Given this list of marker genes Tesc, Chi3l1, Il34, Xbp1, Gsdmd, Cdk4, Lrp1, Wnt11, Rbm22, Larp1, Card11, Mapk14, Ahi1, Cd86, Ly96, L3mbtl3, Mapk13, Mettl8 (NCBI Gene Id 228019), Ago3, Anxa1, Edar, Slc11a1, Mir23a, Grhl3, Kmt2a, Il17d (NCBI Gene Id 239114), Fcgr1, Rftn1, Kdm2a, Mir301, Slc26a9, Mef2c, Ogg1, Polr2a, Lcor, Sulf2, Mycn, Ptpn22, Ago2, Gdnf, Hif1a, Xcl1, Riok3 (RIO kinase 3), Camp, Cd40, Dnd1 (NCBI Gene Id 21746), Prr16, Iqgap3, Dkk1, Cd200 (CD200 molecule), Itga2, Plxnb2, Garin5a, Ythdf3, Slamf1, Oas1d, Cpeb3, Brca1, Rbm14, Nmbr, Nkx2-5, Mir505, Trappc2, Ngrn, Akap6, Il17rc, Dnaja4, Cd209d, Zc3h14, Hgf, Ago1, Stoml2, Foxp3, Whrn, Nup98, 4930480E11Rik, Cd40lg, Samd4, Tnp1, Icosl, Gsk3a, Mbl2, Ccl19, Sh3pxd2b, Il27ra, Il15, Smyd5, Boll, Hnf1a, Alkbh1, Cadm1, Gm7324, Apobec1, Il13, Unc93b1, Wnt7b, Csf2, Tlr7, Clec12a, Fcgr3, Adam3, Csf1, Cnbp, Slc38a2, Nlrp1b, Eif3d, Ntrk3, Tmed2, Rhbdd1, 4931414P19Rik, Vegfd, Hnrnpc, Erbb2, Samd1, Il20rb, Il12rb1, Sgms1os1, Cd209b, Sh3bgrl, 6030468B19Rik, Alox8, Nsun5, Erbb3 (erb-b2 receptor tyrosine kinase 3), Prkca, Flt3, Kpna6, Cnn2, Nkx2-1, Hmgb1, Runx2, Wdr77, Nr5a2, Cxcl17, Klk5, Cd55b, Pkd2, Rbm4b (NCBI Gene Id 66704), Kdm1a, Ptk2b, Reg1, Il6, Eif4g2, Igf2bp3, Cd36, Ceacam20, Psg18, Ifi203-ps, Id4, Frmd8, Robo1, Pms2, Smarcd1, Ptafr (platelet-activating factor receptor), Pcif1, Aldh1a2, Cd44, Sting1, Eif4g1, Prg3, Sphk2, F2rl1, Hspb1, Ptgfr, Crhr2, Alkbh4, Adam8, Mzb1, Myocd, Adtrp, Mapk3 (NCBI Gene Id 26417), Fgfr4, Mmp8, Abcc8, Irak3, Rpl23, Nat10, Rpl5, Prkdc, Tlr3, Ash2l, Slc35a4, Adam17, Ifi213, Cebpb, Lin28a, Gsk3b, Epx, Prkch, Tgfbr3, Nodal, Pqbp1, Etv2, Gria1, Zc3h12a (zinc finger CCCH type containing 12A), Mapk1, Ppard, Ccl1, H2-Q7, Lrrk2, Timm23, Mapk8, Nos2, Hoxa5, Rbm10, Anxa2, Ccn1, Adra2a, Fam98a, Nod1, Adam19, Hnrnpa0, Pde2a, Panx3, Bsg, Dhx33, Tmem119, Trp53, Smad4, Rasgrp1, Apob, Stox1, Mcoln2, Pla2g3, Zfpm1, Rpusd3, Chuk, Pdcd5, Hnf4aos, Pibf1, Stat5a, Ifngr1, Klrk1, Serpinb7, Rps7, Dnmt3b, Tnfrsf14 (NCBI Gene Id 230979), Pip, Nr1i2, Cyrib, Cd6, Gjc2, Bmp6, Mir184, Phb1, Ephb2, Sirt7, Elane, Exosc6, Barhl2, Mkx, Lck, Dhx34, Casp8, Tnfrsf1a, Cyp2j6, Setx, Tnfsf9, Npm1, Fam47c, Mir361, Cd160, Hes1, Prpf19, Lrrfip2, Fus, Tarm1, Ripk1, Hyal2 (hyaluronoglucosaminidase 2), Hnrnpab (heterogeneous nuclear ribonucleoprotein A/B), Rbp4, Il4ra, Trem2, Oas3, Wnt7a, Men1, Prkn, Tada3, Cd2, Mtor, Rab3gap1, Smad2, Ngf, Nck2, Arfgef2, Cd28, Chia1, Tob1, Cdh3, F2r, Smo, Sash3, Ccl4, Trmt112, Lef1, Il17a, Otud6b, Mup5, Cyp3a13, Isl1 (ISL1 transcription factor, LIM/homeodomain), Hnrnpa1, Myh9 (myosin, heavy polypeptide 9, non-muscle), Dgkq, Fn1, Uqcc2, Serp1, Eif5a2, Il2rg, Slc6a4, Ctcf (CCCTC-binding factor), Card9, Dicer1, Pdgfb, Tet1, Dlk1, Hk1, Flot1, Creb3l2, Raet1d, Agtr1a, Plgrkt, Hinfp, Eloc, Tlr4, Pycard, Zbtb20, Hpn (hepsin), Tlr5, Rarg, Plscr1, Nkx2-2os, Klk7, Ppp3ca, Itgb3 (integrin beta 3), Rif1, Pkp3 (NCBI Gene Id 70182), Mpl, C5ar1 (complement component 5a receptor 1), Trim56, Nfe2l2, Il2, Hand2, Il23a, Trub1, Eif4a3l2, Pid1, Slamf6, Nwd1, Cd84, Slc39a5, Trim6, Crh, Nox1, Il4, Eif4enif1, Wnt16, Pnp, H2-M3, Mir18, Ifnb1, Ifih1, Atmin, Rbpj, Gimap5, Cebpg, Arnt, Pink1, Il9, Nsun4, Spn, Kpna2rt, Fgf2, Gper1, Dhx29, Akt1, Hnrnpd, Rbmyf6, Malt1, Tigit, Rbm46, Dgcr8, Tnfsf11, Nras, Atf2, Drosha (NCBI Gene Id 68645), Usp16, Ltb, Hilpda, Phb2, Elavl1 (NCBI Gene Id 97501), C1qtnf4, Tcf3, Prdx6b, Batf, D1Pas1, Mmp14 (NCBI Gene Id 17387), Hnf4a, Adam2, Sirt1, Pla2r1, Hspa8, Agpat1, Pabpc1, Gdf2 (NCBI Gene Id 12165), Rdx, Rbmxl1, Fgfr2, Il12rb2, Actg2, Panx1, Htr2b, Sphk1, Mndal (myeloid nuclear differentiation antigen like), Scrib, Pik3r1, Lin28b, Eda, Lrrc32 (leucine rich repeat containing 32), Ldlr, Ikzf1, Vdr, Cd244a, Nlrp9b, Wnt5a, Dnmt1, Pagr1a, Cd3e, Sptbn1, Eif2ak4, Tank, Rlf, Adar, Ifnar1, Pou3f3, Map2k2, Vps72, Arrb2, Tmem135, Musk, Nfkb1, Gas6, Trub2, Pomc, Tgfb1, Cldn5 (NCBI Gene Id 21920), Foxp1, Mylk2, Ccr7, Gata5, Pnp2, Pik3cd, Pth, Map3k7, Rnf207, Krt17, Jag1, Traf3ip2, A1cf, Ccbe1, Osr2, Pou2f2, Mettl5, Prmt1, Ptprj, Pou2af1, Prg2, Myd88, Srpk2, Il12a, Kat2a, Cdh5, Lamp3, Rps6ka2, Kdm3a, Rpl11, Rab7b, Bmyc, Mapkapk2, Hnrnpll, Rbm3 (RNA binding motif (RNP1, RRM) protein 3), Sulf1, Msh2, Hspd1, Mup11, Amh (NCBI Gene Id 11705), Serpine1, Ins2, Tbx21, Med1, Fam47e, Aicda, Fshb, App, Ythdf2, Ccdc88b, Cebpe, Nlrp1a, Slc24a4, Ptger4, Irf8, Casp1, Smad1, Rhox13, Ncoa3, Wnt6, Tfrc, Rps3 (ribosomal protein S3), Larp4, Habp4, Stx4a, Eif2ak3, C3ar1, Aire, Eif6, Hpx, Slc24a3, Brd7, Sox10, Cdkn2a, Adm2, Piwil2, Lacc1, Lrp3 (NCBI Gene Id 435965), Qki, Pabpc1l, Zar1, Trim65, Pparg (peroxisome proliferator activated receptor gamma, NCBI Gene Id 19016), Rps6kb2, Atad5, Bmp4, Emilin1, Crp, Exosc10, Rbfox2, Foxc1, Inhba, Hsf1, Mdk, Hc (hemolytic complement), Zmpste24, Mad2l2, Hfe, Stmp1, Prkd2, Mbp, Mapk9, Ddit3, Rara, Il1rl1, Brdt, Tomm70a, Zswim8, Tusc2, Clec9a, Eno1, Uap1, Tent5b (terminal nucleotidyltransferase 5B), Ctnnb1, Mirlet7a-1, Chrna7, Thrap3, Il5, Prdx6, Dnajc3, Trp53inp1, Rbmyf3, Tlr1, U2af2, Vsir, Spi1, Wnt3a, Mef2a, Ddx1, Polr3c, Nrl, Nr1h4, Mir452, Ffar2, Peli1, Tnc, Il18r1, Sgf29, Rbbp5, Park7, Agr2, Cldn3, Bcl10 (B cell leukemia/lymphoma 10), Rbmyf9, Avpr2, Ddx39b, Igf2bp2, Tlr8, Mecp2, Sry, Crtam, Csf1r, Afap1l2, Mir125b-2, Sod1, Pld1, Oas1c, Eif5a, Cd300c2, Nfatc1, Osm, Ankrd42, Hoxd3, Lilra5, Trpv4, Rela, Gapdh, Nlrp3, Nr0b2, Il17f (NCBI Gene Id 96930), Tet2, C1qtnf3, Iapp, Met, Il16, Bmp7, Sox17, Pik3cb, Phactr1, Lum, Pym1, Polr3f (polymerase (RNA) III (DNA directed) polypeptide F), Syncrip, Rps4x, Fam76b, Rsad2, Tirap, Hnrnpk, Egf, Epb41l4b, Cyba, Hdac2, Mup3, Oas1h, Dhx36, Mir466l, Usp50, Ar, Ptgis, Cntn1, Ncl, Ppp1r15a, Txk, Ets1, Id1, Eif4a3, Shh, Oas1g, Dll4, Rbm24, Clns1a, Fxr2, Dyrk1a, Atp13a2 (ATPase type 13A2), Cux2, Adcyap1, Prkcz, Atf3, Fcer1g, Igf2bp1, Dennd1b, Paip1 (NCBI Gene Id 218693), Cd83, Crebbp, Sox4, Kdm6a, Lpl, Ddx3x (NCBI Gene Id 236681), Plcg2, Itgb8, Arx, Bcl11a, Itga3, Fzd5, Spon1, Upf3a, Fastkd3, Eif4g3 (eukaryotic translation initiation factor 4 gamma, 3), Smarca4, Mark1, Wnt8b, Rora, Usp22, Tradd (NCBI Gene Id 71609), Setd1a, Klf4, Csde1, Pkp1, Jmjd4, Lurap1, Tek, Chil5, Itgax, Rad21, Stat1, Bmpr1a, Pdcl3 (NCBI Gene Id 96896), Eif2ak2, Fev, Tnfrsf4, Adipoq, Myt1, Eno1b, Ccl3, Bcl3, Il1rl2, Fadd, Cd27, Tnfsf18, Tmem106a, Trp53bp1, Il1a, Vip, Cdk6, Nog, Twist1, Il27, Traf3, Runx1, Fcer2a, F3, Agpat2, Rps27l, Ep300, Mmp12, Ctnnd1, Nos3, Mavs, Ctsh, Sox9, Abl2, Defb25, Rnf135, Sox8, Cd226, Smarcb1, Tent5c, Mettl14, Usp21, Hand2os1, Tgfb2, Ogt (O-linked N-acetylglucosamine (GlcNAc) transferase (UDP-N-acetylglucosamine:polypeptide-N-acetylglucosaminyl transferase)), Trim15, Tent2, Cirbp, Ephx2, Ifi209, Il18 (NCBI Gene Id 16173), Glyr1, Dazap1, Mir324, Snrnp70, Nr3c1, Actc1, Cd1d1, Bcdin3d, Il17rb, Terf2, Snw1, Wnt10a, Prkag1, Guf1, Tgfb3, Il17c, Kpna7, Elavl4, Sgms1, Hmgn5, Oas1e, Poldip3, Carmil2, Fubp3, Rpusd4, Spry2, Tgfbr1, E2f1, Slirp, Panx2, Mafg, Btk, Notch1, Calcr, Mst1, Rab2b, Exosc3, Rps6kb1 (NCBI Gene Id 72508), Fgf9, Ulbp1, Nrde2, Tmed10, Pax6, Alox12b, Nat8b-ps, Astl, Itk, Mefv, Gapdh-ps15, Prdm1, Gata3, Casr, Zc3h10, Zpr1, Bag2, Tbx1, Cd14, Tfap2a, Cd37, Trmt10c, Apoa2, Ager, Jak2, Tug1, Kdm4a, Optn, Egr1, Rock2, Crnde, Rbm4, Stat6, Mettl3, Tnfsf15, Stat4, Fgf8, Slc7a5, Uhmk1, Opa1, Tlr9, Polr3d, Ripk2, Atp6ap2, Ccl5, Ifng, Il1rap, Noct, Ttbk1, Drd2, Havcr2, Kdm1b, Padi2, Lmntd2, Odam, Clec3b, Ythdf1, Tbc1d23, Zfp683, F12, Rbmxl2, 4930402K13Rik, Tent4a, Hmga2, Wars1, Celf1, Tra2a, Cd276, Mir125b-1, Aim2, Nr2e3, Atad2, Ikbke, Pde4b, Pawr, Tut4, Cav1, S100a13, Cntn2, Lbp, Gpsm3, Tlr6 (toll-like receptor 6), Ptbp1, Tnf, Cldn19, Rmnd1, Tcf23, Grk2, Hmgb2, Klf1, Ccl2, Agt, Etv4, Mir133b, Slc2a10, Selenok, Nicol1, Cx3cl1, Akap12, Ncbp1, Kmt5b, Wnt3, Naip5, Trim27, Hcfc1 (NCBI Gene Id 15161), Gcgr, Mbip, C3, Mir133a-1, Myb, Hnf1b, Nfatc4, Htr2a, Znhit1 (zinc finger, HIT domain containing 1), Nck1, Ybx1, Mirlet7a-2, Pcbp1, Flt4, Nkd2, Mup4, Celf4, Mif, Rims2, Kras, Pik3r3, H2-T23, Polr3g, Setd4, Dtnbp1, Nrxn1, Akirin2, Rab1a, Obi1, Kmt5c, Gbp5, Tslp, Tent4b, Phf2, Il13ra1, Nbas, Erp29, Cdk1, Mup2, Ifi214, Kat8, Ercc6, Mpv17l2, Myc, Kit, Tmf1, Tmed10-ps, Kat7, Vegfa, Eif4a3l1, Lgals9, Irf7, Zcchc13, Ret, Cd81, Atad2b, Scx, Ftx, Ddx21, Ppm1f, Ttn, Plp1, Spon2, Gpi1, Irf4, Nr1h2, Dll1, Agtr2, Heg1, Fermt1, Sorl1, Ppargc1a, Letmd1, Hgs, Vtcn1, Fcgr2b, Gbp4, Tent5a, Zfp36, Pou4f1, Ptgs2, Tra2b, Khdrbs3, Coa3, Ifi207, Kpna2, Rbbp9, Prkcq, Ntsr1, Aif1, P2rx7, Pkm, Srsf1 (NCBI Gene Id 70724), Irx1, Chil6 (NCBI Gene Id 279114), Tbk1 (TANK-binding kinase 1), Kdm5b, Mapk11, Trim24, Nat8f7, Abcf1, Src, Gapdhrt2 (glyceraldehyde-3-phosphate dehydrogenase, retrotransposed 2), Maz (NCBI Gene Id 17188), Ddrgk1, Ntrk2, Shld3, Ramp2, Acta1, Oas1a, Nlrc4, Kdm4c, Ticam1, Snf8 (SNF8, ESCRT-II complex subunit, homolog (S. cerevisiae)), Apobec2, Eif3e (eukaryotic translation initiation factor 3, subunit E), Kif1b, Ttc21b, Nlrp10, Atm, Psen1, Nat8f1, Phf8 (PHD finger protein 8), Tle1, Cd55, Upf1, Upf3b, Mir155, Pgc, Cpeb1 (cytoplasmic polyadenylation element binding protein 1), Eif2b5, Irf3, Cd74, Rims1, Bmp2, Rel, Rbm47, Vps35, Clcf1, Alox12, C1qtnf1, G3bp1, Chil4, Clec5a, Wbp2, Chil3, Angptl8, Hsp90aa1, Nkx3-1, Hmces, Avp, Il12b, Prmt5, Ccr2, Arrdc4, Tent5d, Nfat5, Dazl, Mlh1, Pdcd5-ps, Calr, Eng, Lamtor5, Ins1 (NCBI Gene Id 16333), Il36a, Tarbp2, Cd274, Prkd1, Rxra, Star, Adora2b, Ly9, Niban1, Gsn (gelsolin), Arid5a, Atf4, Tnfsf13, Dnmt3l, Inava, Maf, Prkab1, Mitf, Srsf5, Eif1 (eukaryotic translation initiation factor 1), Olfm1, Traf5, Il21 (NCBI Gene Id 60505), Hspa1b, Eef2, Cyp26b1, Rtn4, Cd1d2, Dlg1, Fxr1, Nfam1, Pdcd10, N6amt1, Braf, Hras, Larp4b, Wdr5, Laptm5, Mycs, Nsd2, Mt3, Elob, Nmb, Lep, Lmna, P2ry2, Mettl16, Secisbp2, Clec7a, Il10, Dhx58, Clnk, Btnl2, Rgcc, Traf3ip3, Tnfrsf13c, Mir3960, Pou5f1, Nfatc2, Zfp804a, Traf2, Mrps27, Rock1, Thbs1, Hpse, Mir744, Ybx2, Meioc, Il1b, Lcn2, Zc3hav1, Il23r, Med23, Fubp1, Ctcfl, Id3, Zfp580, Tfr2, Serpinf2, Yap1, Nfil3, Klrh1, Ikbkg, Tlr2, Osr1, Fam98b, Il7r, Clec4e, Creb1, Mup1, Sema7a, Ern1, Vstm2a (V-set and transmembrane domain containing 2A), Smn1, Bmpr1b, Il1r1, Pmp22, Lims1, Shld2, Psg22, Tyk2, Dnajb9, Myom1, Casp4, Ptpn11, Rbmx, Ifi203, Hmx2, Appl1, Ifi206, Macroh2a1, Zfp64, Slc22a2, Kat6a, Mir135a-2, Ocln, Sec16b, Taf15, Clec4n, Ssb, Nkx2-2, Irf5, Crlf2, Traf6, Tnfsf4, Foxd1, Ccr5, Fcer1a, Nat8, Tardbp, Yy1, Vash1 (NCBI Gene Id 263410), Tescl, Rbmy, Map2k1, Stap1, Mir21a, Xiap, Fgf4 (fibroblast growth factor 4), Cdk5rap1, Zcchc4, Scamp5, Vim, Il36g, Paxip1, Nrg1, Polr3a, Igf1, Med26, Celf3, Fcnb, Plcb1, Ptges3, Acvr1b, Ucn, Abl1, Irf1, Afdn, Msn, Blnk, Mustn1, Rbms3, Gapdhrt, Stat3, Nr4a3, Actg1, Rab27a, Tnfrsf8, Dlx5, Ccl20 (NCBI Gene Id 20297), Cntf, Plag1, Cgas, Ubr5, Ptprc, Gprc5b (NCBI Gene Id 64297), Hnrnpu, Angpt1, Clu, Il33, Oas1b, Ffar3, Bmpr2, Cd34, Rcc1l, B2m, Irak1, Stat5b, Ticam2, Gdf7, Il17ra, Oas2, Syk (NCBI Gene Id 20963), Ighd, Cited1, Khdrbs1, Gata4, Setd2, Fcna, Lif, Il36b, Prkaa1, Rpl26 (ribosomal protein L26), Tsix, Ido1, Cd46, Tet3, Smad3 (SMAD family member 3), Cyp1b1, Gimap3, Pias3, Postn, Sox11 (NCBI Gene Id 67779), Psg23, Fbln1, Il17b, Arhgef2, Ptger3, Axin2, Trim32, Glmn, Gja1, Nr5a1, Ccn2 (cellular communication network factor 2), Oas1f, Cited2, Il7, Meltf, Zfp750, Apex1, Lta, Cebpa, Zcchc3, Rest, Mdm2, S100a10, Scimp, Ezr, Isg15, Il6ra, Fastkd2, Zp3, Ereg, Pten, Gsdma3, Polr3b, Mfn2, Sp1, Calcoco1, Ovol2, Nod2, Timm17a, Rigi (NCBI Gene Id 230073), Fmr1, Wt1, Gata2, Pou3f1, Rbmyf1, Tnp2, Sfrp4, Ank3, Polr2g, C1qbp, Nts, Pde4d, Fgr, Galnt2, Acta2, Tcf12, Nampt, Bmp10, Ank2, Rbm38, Akt2, Cybb, Tyrobp, Rbm20, Zbtb7b, Ccm2l, Id2, Ifi208, Dpy30, Angel2, Mir98, Ramp3, Dhx9, Shld1 (shieldin complex subunit 1), Fuz, Klre1 (NCBI Gene Id 243655), here is a description of the gene set: Any process that increases the frequency, rate or extent of gene expression. Gene expression is the process in which a gene's coding sequence is converted into a mature gene product (protein or RNA). Mouse Gene Set: GOBP_POSITIVE_REGULATION_OF_GENE_EXPRESSION studied in species Mus musculus